The following is a description of a gene set: Genes containing one or more binding sites for (Ahcy or Ahcyl) in their promoter regions (TSS -1000,+100 bp) as identified by GTRD version 20.06 ChIP-seq harmonization. from publication Yevshin I, Sharipov R, Kolmykov S, Kondrakhin Y, Kolpakov F (PMID 30445619) Mouse Gene Set: AHCY_AHCYL_TARGET_GENES studied in species Mus musculus, and this is the list of marker genes: Cdkal1, Mcoln1, Tex15, Samd9l, Selenof, Ndufs7, Irf2bp2, Khdc4, Mrps11, Kdm1a, Gm28535, Mtfr1l, Lpcat3, Itgb3bp, Plekhg4, Hmg20a, Frat2, Hycc2, Rps6, Immt, Gm11592, Ptbp3, Srsf6, Snx5, Mgme1, Msl2, Spg11, Pou2f1, 3000002C10Rik, H3c7, Zc3hc1, Dsn1, Hp1bp3, 2810013P06Rik (NCBI Gene Id 67206), Ccng2, Hook3, Asnsd1, Smim8, H4c4, 1110019D14Rik, Marchf7, Kmt2a, Tatdn3, Efcab7, Cdca7, Rmi2, Ppm1a, Mrpl46, Hdgfl3, Epm2a, 1110025M09Rik, Baz2b, Gm6999 (predicted gene 6999), Cenpu, Tal1, Rnf170, Rxylt1, Rpl5, Oxr1, Pxk, Gm32950, Tspan9, Wdfy1, Zfp866, Cdk5rap1, Asb7, Ets2, Rps14, Scaf11, Dbf4, Lrp12, Mterf4, Gtf3c6, Atp11b, Wac, Psmc2, Filip1l, Cpsf1, Grb10, Iqcg, Snrnp70, Snhg6, Rpl35a (NCBI Gene Id 68254), Sf3a2, Mrpl44, Prkd3, Rictor, Bcl6, Nsl1, Sec24b, Rad54b, Sacs, Mettl15, Gtf2a1 (general transcription factor II A, 1), Rpl22l1, Prrc2a, Arid1a, Hs2st1, Lins1, Rbks, Prelid1, Gm5447, Exoc2, Zscan12, Nme6, Ep300, Rad51b, Dnajc2, Gm15784, Mtf2, Smad2, Nckap1, Gm26854, Champ1, Xpot, Zfp146, n-R5s185, Smim30, Snord3a, Gm5113, Tex14, Snrpb, Nop58, Ank1, Ndufb3